The following is a description of a gene set: species: Mus musculus Any process that results in a change in state or activity of a cell or an organism (in terms of movement, secretion, enzyme production, gene expression, etc.) as a result of a laminar fluid shear stress stimulus. Laminar fluid flow is the force acting on an object in a system where the fluid is moving across a solid surface in parallel layers. As an example, laminar shear stress can be seen where blood flows against the luminal side of blood vessel walls. Mouse Gene Set: GOBP_RESPONSE_TO_LAMINAR_FLUID_SHEAR_STRESS, and this is the list of marker genes: Klf2, Mapk7, Xbp1, Ass1 (NCBI Gene Id 11898), Smad6, Abca1, Smad7, Nfe2l2, Klf4, Tgfb1, Ace